Given this list of marker genes Plxna4, Shank3, Prickle2, Appl1 (NCBI Gene Id 97938), Ctbp2, Sdf4, Prickle1, Rab3a, L1cam, Mpp2, Syngap1, Cadm1, Nlgn1, Cntnap2, Sort1, Sema3a, Rimbp2, Bsn, Dgkz, Itgb3, Cbln3, Erc2, Erc1 (ELKS/RAB6-interacting/CAST family member 1), Ophn1 (NCBI Gene Id 94190), Pclo, Rims2, Shank1, Cbln1, Dlg1, Dlg2, Hspa8, Cbln2, Adgrl3, Grn, Rapsn, Nrxn1, Itgb1, Csmd2, Arf6, Adgrb3, Rims1, C1ql1 (NCBI Gene Id 23829), here is a description of the gene set: Mouse Gene Set: GOBP_MAINTENANCE_OF_SYNAPSE_STRUCTURE species: Mus musculus A process that preserves the structural organistation and orientation of a synaptic cellular component such as the synaptic cytoskeleton and molecular scaffolds.